The following is a description of a gene set: Catalysis of the hydrolysis of a peptide bond not more than three residues from the N- or C-terminus of a polypeptide chain by a mechanism in which water acts as a nucleophile, one or two metal ions hold the water molecule in place, and charged amino acid side chains are ligands for the metal ions. studied in species Mus musculus Mouse Gene Set: GOMF_METALLOEXOPEPTIDASE_ACTIVITY, and this is the list of marker genes: Lta4h, Mep1a, Cpa2, Anpep, Mmp16, Cpa6, Agbl5, Mme, Vash1, Dpep1, Xpnpep2, Trhde, Nudt16, Agbl4, Ace2, Cpa3, Cndp2, Prcp, Agtpbp1, Cpa5, Cpa4, Vash2, Lnpep, Aebp1, Cndp1, Naalad2, Npepl1, Rnpepl1, Ermp1 (endoplasmic reticulum metallopeptidase 1), Pepd, Cpz, Xpnpep3, Matcap1, Cpd, Cpa1, Cpe, Rnpep, Dpp3, Aopep, Cpq, Npepps, Agbl3, Metap1d, Adam10, Cpb2, Lap3, Dpep2, Agbl1, Enpep, Xpnpep1, Folh1, Cpn1, Metap2, Ace, Metap1, Agbl2, Cpm, Mmp14, Cpb1, Prep, Adam17, Erap1